The following is a description of a gene set: Human Gene Set: REACTOME_ADENYLATE_CYCLASE_INHIBITORY_PATHWAY studied in species Homo sapiens Adenylate cyclase inhibitory pathway, and this is the list of marker genes: ADCY1, GNAI1, ADCY8, GNAI2, ADCY4, ADCY6, GNAL, ADCY5, ADCY2, ADCY3, ADCY7, ADCY9, GNAI3, GNAT3